Given this list of marker genes IRF8, TET2, RPL26, RPL18, CSF3R, SF3B1, KIT, SRSF2, ASXL1, here is a description of the gene set: studied in species Homo sapiens Abnormal number of granulocyte precursors Human Gene Set: HP_ABNORMAL_NUMBER_OF_GRANULOCYTE_PRECURSORS